The following is a description of a gene set: Mouse Gene Set: CUI_T_CELL_CD8_IL17D_RESPONSE_DN Cytokines mediate cell-cell communication in the immune system and represent important therapeutic targets. A myriad of studies have highlighted their central role in immune function, yet we lack a global view of the cellular responses of each immune cell type to each cytokine. To address this gap, the authors created the Immune Dictionary, a compendium of single-cell transcriptomic profiles of more than 17 immune cell types in response to each of 86 cytokines (>1,400 cytokine-cell type combinations) in mouse lymph nodes in vivo. A cytokine-centric view of the dictionary revealed that most cytokines induce highly cell-type-specific responses. For example, the inflammatory cytokine interleukin-1β induces distinct gene programmes in almost every cell type. A cell-type-centric view of the dictionary identified more than 66 cytokine-driven cellular polarization states across immune cell types, including previously uncharacterized states such as an interleukin-18-induced polyfunctional natural killer cell state. from publication Cui A, Huang T, Li S, Ma A, Pérez JL, Sander C, Keskin DB, Wu CJ, Fraenkel E, Hacohen N (PMID 38057668) studied in species Mus musculus Genes negatively differentially expressed in cell type: CD8+ T cell upon treatment with cytokine: IL-17D in mouse lymph nodes in vivo., and this is the list of marker genes: Klf2, Hspa1a, Klf6, Cd69, Btg1, Junb, Tsc22d3 (TSC22 domain family, member 3), Zfp36l2 (zinc finger protein 36, C3H type-like 2), Jun, Fos, Hspa1b